The following is a description of a gene set: Human Gene Set: GSE411_UNSTIM_VS_400MIN_IL6_STIM_MACROPHAGE_DN species: Homo sapiens Genes down-regulated in macrophages: untreated versus IL6 for 400min. from publication Lang R, Pauleau AL, Parganas E, Takahashi Y, Mages J, Ihle JN, Rutschman R, Murray PJ (PMID 12754506) Effects of SOCS3 on the transcriptional response of bone marrow-derived macrophages to IL-6. Fetal liver cells from SOCS3+/+ or SOCS3-/- embryos were used to reconstitute recipient mice. Donor derived bone marrow from these mice was differentiated to macrophages. Macrophages were either unstimulated, or stimulated for 100 or 400 minutes with 10 ng/ml IL-6., and this is the list of marker genes: NR4A3, RARB, PGPEP1, SYCE2, TTC39B, GRPEL2, NSMCE2, SEPTIN12, POLG, PRRC2A, REV3L, LSM14A, CWC15, TLCD2, EIF5B, RPS27L, ERCC6L2, UBE2M, MAP2, PIDD1, IQCB1, TNNT1, SCIN, RAB9A, GNG7, SLAMF7, MTX2, ACBD6, C1orf53, PFKFB1, SNHG32, SASS6, ELP4, MBIP, CCDC112, CS, LY75, MICU2, BTF3L4, HEBP2 (heme binding protein 2), CRPPA, DHRS1, PLEKHA5, SIK3, GLA, ARL4A, MRPL27, NPAT, ANKRD40, PFDN6, KSR1, GCA (NCBI Gene Id 25801), CFAP126, CHST7, MRPL17, TUBB, ITGB1BP1, TMEM256, CHDH, POLR3K, AP1S2, IFT46, MED12L, CSE1L, WDR90, PRMT5, UCP2, CIBAR1, NUDT14, CFDP1, DIS3, PDE3B, PSMD13, DBN1, TDP1 (NCBI Gene Id 55775), MRPL32, AKIP1, UBAP1, PEBP1, YAF2, CBX2, ZNF664, POC5, SCCPDH, OSGIN2, JPT1 (Jupiter microtubule associated homolog 1), VAMP7, USP7, HMBS, SLAIN1, LPXN, FAAP24, TPK1, ANKMY2, MCTP2, TEX9, TMEM100, IFT57, RAD50, SLX9, NUDCD1, ALG8, ACSM3, TRA2B, NOP16 (NOP16 nucleolar protein), RAMAC, BBS2, CCDC34, FBXO10, LTK, CRLS1, PPFIBP1, TMEM41B, NHP2, FAM83G, CNOT9, TYW1, PTPN2, FAM133B, CENPU, EXOC4, TRIM33, SFMBT1, ZWINT, FARS2, ZNF496, GRHL1, TBC1D7, EPB41, BEND3, SLC16A1, BATF, GRHPR, NAA50, EPB41L5, ERI1, RBKS, ZNF76, PMF1, NUDC, HMGA1, CTC1, NACC1, NMNAT3, SCLT1, TERF2IP, GARS1, UBE2D2, NANS, SLC25A18, CDIN1, KPTN, F9, MPHOSPH6, GGT7 (NCBI Gene Id 2686), NR4A1, NAA15, NMT1, DCP2, NOL7, CUTA, MSL3, PDS5B, DDIAS (DNA damage induced apoptosis suppressor), HAUS1, DMRT2, SKAP2, ANGPTL4, SFPQ, CEP76, DEK, RNASEH2A, CACNA1D, DNAJA2, MIS18A, KCNK5, IGF2BP3, SLC29A1, SLC66A3, ECHDC1, NAF1, SMC3, IFT80, C19orf53, PRDX6, RBBP8, OLA1, CENPQ, BPGM, UBQLN1, SLC4A8, ZMAT5, DNAJC19, MTSS1, LHFPL4, FDFT1, RHOH, ABCG4, RPA3, CMPK1